Given this list of marker genes Il13ra1, Arfrp1, Rhoc, Rab5b, Gyg1, Gnb2, Vim, Tubb5, Tspo, B3gat3, Cd74, here is a description of the gene set: Cytokines mediate cell-cell communication in the immune system and represent important therapeutic targets. A myriad of studies have highlighted their central role in immune function, yet we lack a global view of the cellular responses of each immune cell type to each cytokine. To address this gap, the authors created the Immune Dictionary, a compendium of single-cell transcriptomic profiles of more than 17 immune cell types in response to each of 86 cytokines (>1,400 cytokine-cell type combinations) in mouse lymph nodes in vivo. A cytokine-centric view of the dictionary revealed that most cytokines induce highly cell-type-specific responses. For example, the inflammatory cytokine interleukin-1β induces distinct gene programmes in almost every cell type. A cell-type-centric view of the dictionary identified more than 66 cytokine-driven cellular polarization states across immune cell types, including previously uncharacterized states such as an interleukin-18-induced polyfunctional natural killer cell state. from publication Cui A, Huang T, Li S, Ma A, Pérez JL, Sander C, Keskin DB, Wu CJ, Fraenkel E, Hacohen N (PMID 38057668) Genes positively differentially expressed in cell type: MigDC (migratory dendritic cell) upon treatment with cytokine: TRAIL in mouse lymph nodes in vivo. Mouse Gene Set: CUI_MIGDC_TRAIL_RESPONSE_UP species: Mus musculus